Given this list of marker genes FAR1, AWAT1, AWAT2, GNPAT, AGPS, FAR2, DHRS7B, here is a description of the gene set: studied in species Homo sapiens Waxes are esters of long chain fatty acids and long chain fatty alcohols that play an important role in protecting the skin surface from drying and abrasion (Cheng & Russell 2004a,b). Plasmalogens are an abundant subclass of phospholipids. While their functions are not well understood, defects in their metabolism are associated with serious human disease (de Vet et al. 1999; Nagan and Zoeller 2001). The biosynthesis of these two classes of molecules both start with the reduction of palmitoyl-CoA (PALM-CoA) to hexadecan-1-ol (HXOL) so it is convenient to group them here. Reactome Pathway: Wax and plasmalogen biosynthesis part of: Metabolism of lipids